The following is a description of a gene set: studied in species Mus musculus A process in which a protein is transported to, or maintained in, a location within the perinuclear region of the cytoplasm. Mouse Gene Set: GOBP_PROTEIN_LOCALIZATION_TO_PERINUCLEAR_REGION_OF_CYTOPLASM, and this is the list of marker genes: Aktip, Rnf26, Rnf26rt, Hook1, Hook3, Fhip1a, Sqstm1, Septin14, Fhip1b, Hook2 (NCBI Gene Id 319853)